Given this list of marker genes NAPG, HNRNPU, UGT2B10, SLC2A9, F2RL2, MYO5A, SKAP2, SIGLEC14, SMAP1, ZFP3, UBE2D1, ZNF680, WDR48, JAZF1, PHF2, GNRH1, ANKRD42, RNF182, FBXW2, FSTL1, SYNJ1, CDKN2D, ARF4, FBXO43, RCAN2, PIKFYVE, ZDHHC19, IGDCC4, SERPINA1, BRCA1, AQP4, GGA2, GOLIM4, CLASP2, OR12D3, BARX2, SDR9C7, CD274, GPALPP1, TFDP1, KCNV1, SH3BGRL3, PTGES3, here is a description of the gene set: from publication Chen Y, Wang X (PMID 31504780) Human Gene Set: MIR4506 Genes predicted to be targets of miRBase v22 microRNA hsa-miR-4506 in miRDB v6.0 with MirTarget v4 prediction scores > 80 (high confidence targets). studied in species Homo sapiens